Given this list of marker genes WDR19, PIGA, HMGCL, GLUL, CORIN, CFHR1, TNFRSF11B, SLC2A2, ACAT1, RRAGC, XDH, ATP5MK, ERCC4, ACAD9, SLC25A36, REN, MRPS7, GRHPR, CPS1, STX5, COQ4, POLG, ATP7B, FBXL4, MT-ATP8, ACADM, LMAN1, NPHP1, LMNA, SLC4A2, ASL, GPHN, CAD, INVS (NCBI Gene Id 8014), ATP5F1E, UMOD (uromodulin), ATP5F1B, MCCC1, SEC61A1, COQ7, MMUT, LRPPRC, NDUFA6 (NADH:ubiquinone oxidoreductase subunit A6), IFT56, ADRA2A, MRM2, STOX1, ZPR1, CFI, PCCA, PKD2, COX6B1, MMAB, PCBD1, ARG1, OTC, MOCS2, SLC37A4, ATPAF2, CC2D2A, MOCOS, IFT140, UQCRH (ubiquinol-cytochrome c reductase hinge protein), DLD, SLC7A7, SARS2, SLC34A1, MUC1, TREX1, HLCS, GANAB, PNP, HADH (NCBI Gene Id 3033), ERCC8, ATP5F1D (ATP synthase F1 subunit delta), AVPR2, SLC22A5 (solute carrier family 22 member 5), BTD, ATP5F1A, NDUFAF6, MECP2, DPYS, PFKM, CFH, EHHADH, APRT, FAN1, SLC4A1, PRPS1, PKD1, COL4A3, TSFM, ELP1 (elongator acetyltransferase complex subunit 1, NCBI Gene Id 8518), G6PC1, TNFRSF11A, FBP1, PCCB, GAMT, CFB, PHKA2, RINT1, TYMP, EIF2AK3, C1GALT1C1, GALNT2, UQCRC2, FOCAD, IARS1, ALDH18A1, PPARG, MMACHC, DBH, DNAJB11, MARS1, FLT1, PHKB, IVD, NFE2L2, CFHR3, HADHB, HADHA, ALG9 (NCBI Gene Id 79796), SH2B1, TANGO2, PYGM, SPR (sepiapterin reductase), CCND1, ACADVL, MOCS1, TMEM260, HPRT1, NBAS, ALDOB, SERAC1, CARS2 (NCBI Gene Id 79587), CTNS, MCFD2, ERCC6, MRPS22, TMEM70, CPT1A, MCCC2, SLC25A20, C3, NAGS, SC5D, MYC, HSD17B10, SLC25A13, MLIP (NCBI Gene Id 90523), ALG11, CLDN16, MPV17, HNF4A, SLC22A12, SLC41A1, MTO1, TUFM, SLC25A15, ADAMTS13, ALG5, ASS1, AASS, SLC2A9, GOT2, ALMS1, NT5E, CPT2, PAX2, BICC1, NR1H4, MMAA, GATM, CA5A, GLUD1, OCRL, PDHB, MT-ATP6, HBB, CYC1, SLC25A42 (solute carrier family 25 member 42), CD46, ALG8, THBD, HNF1B, here is a description of the gene set: studied in species Homo sapiens Abnormal circulating nitrogen compound concentration Human Gene Set: HP_ABNORMAL_CIRCULATING_NITROGEN_COMPOUND_CONCENTRATION Any deviation from the normal concentration of a nitrogen compound in the blood circulation.